Given this list of marker genes TGFB1, MIR29B1, CST3, RECK, MIR29C, MIR92A1, DPP4, FAP, MIR98, MIR24-1, TIMP3, here is a description of the gene set: studied in species Homo sapiens Human Gene Set: GOBP_NEGATIVE_REGULATION_OF_EXTRACELLULAR_MATRIX_DISASSEMBLY Any process that decreases the rate, frequency or extent of extracellular matrix disassembly. Extracellular matrix disassembly is a process that results in the breakdown of the extracellular matrix.